Given this list of marker genes CD86, IL6, IL4R, TNFSF4, RSAD2, PRKCZ, CD74, NLRP3, IL18, IDO1, GATA3, CD81, DENND1B, IL33, XCL1 (X-C motif chemokine ligand 1), NOD2, IL4, RARA, here is a description of the gene set: Human Gene Set: GOBP_POSITIVE_REGULATION_OF_TYPE_2_IMMUNE_RESPONSE studied in species Homo sapiens Any process that activates or increases the frequency, rate, or extent of a type 2 immune response.